The following is a description of a gene set: species: Homo sapiens A T cell receptor complex in which the TCR heterodimer comprises gamma and delta chains, associated with the CD3 complex; recognizes antigen directly, without a requirement for processing and presentation by an MHC protein. Human Gene Set: GOCC_GAMMA_DELTA_T_CELL_RECEPTOR_COMPLEX, and this is the list of marker genes: TRGC2, CD247, CD3E, CD3G (CD3 gamma subunit of T-cell receptor complex), TRGC1, TRDC